The following is a description of a gene set: Human Gene Set: ZNF512_TARGET_GENES Genes containing one or more binding sites for (ZNF512) in their promoter regions (TSS -1000,+100 bp) as identified by GTRD version 20.06 ChIP-seq harmonization. studied in species Homo sapiens from publication Yevshin I, Sharipov R, Kolmykov S, Kondrakhin Y, Kolpakov F (PMID 30445619), and this is the list of marker genes: STC2, NAV2, ZNF30, OPTN, LMNB2, MSANTD4, MKRN3, JPX, GRIK5, PARP12, ANKRD24, DPF1, SEZ6L, PDE7B-AS1, MIR320B1, SLC35F5, RAB13, RNU6-1136P, KCNK15, PILRB, ALX4, SELL, EIF2S3, TLE4, PACRGL, KLHL31, NMRAL2P, GATA5, SCNN1B, RNU6-409P, CUL2, SLC25A10, INTS13 (NCBI Gene Id 55726), ZNF512B, KDM2B (NCBI Gene Id 84678), PHC1, MTA2, EPOR, APCDD1L, NIPSNAP2, GSDMA, SCARB1, RNU4-13P, HCG9, ZNF764, LINC01297, HOXC13, NINJ2, MECOM, PTPRS-AS1, ZNF180, ASPHD2, RTN3, STX2, ARL5C, PGA3, SNORD13, FYB1, LONRF3, CYP2B6, NCBP3, HIP1R, ISG20L2, POLE3, STK10, BAIAP2L1, ZNF521, POLR3H, LINC00700, LINC01596, CCDC144NL, LDAH, CD28, TG, ABHD16A, PUDPP2, SCUBE3, DENR, MRPL36, SERBP1P3, ATP6V1G2, ARL4A, NUDT5, KLF5, ARHGAP25, ZMYM3, COTL1, PARS2, CT45A1, ZNF114, ENSG00000236366, RNU2-61P, CLMN, PHLDB1, IST1, SUB1, SOD1, MARK2P11, CRYZL2P, TDRD9, MIR7845, ZNF385A, HOXB3, C4orf3, PDCL3P5, KLF7P1, TRAPPC9, AKR1B10, HMGB3P5, MIR153-1, HM13-AS1, DACH1, SOX6 (SRY-box transcription factor 6, NCBI Gene Id 84363), UGP2, CCNI, SNAPIN, GLYAT, TNFAIP3, ID2, SIRT1, LINC02798, SGK1, KLF7, ELN, CHD9NB, TGFB3, IQGAP2, SCCPDH, MDGA1, CACNA1A, CCDC83, NEK1, TIMM17A, DNM2, NEXN, NOSIP, DLGAP1-AS1, ITGAM, CHST10, HOXD3, ANPEP, HNRNPH2, GAD1 (NCBI Gene Id 50977), LRGUK, CREM, EGR3, IMPA1P1, GABBR1, ZNF528, LEISA1, NOX5, TJAP1, RNU7-196P (RNA, U7 small nuclear 196 pseudogene), HDDC2, ATP5MGP3, ZMIZ2, PPP4R3B, PGAP1, LINC02701, MYOM2, ZFP64, FSIP2LP, NAA20, RNU6-955P, ZNF184, ZC3H4, TNFRSF10B-AS1, TSPAN18, EN1, DCLRE1B, MUC16, PCED1B-AS1, NR2F1-AS1, MROH7-TTC4, TFPI, SHOX2, OR2AT1P, NIF3L1, BTN2A2 (butyrophilin subfamily 2 member A2), SLC7A6, GPC5, RBMS2, MAPKAPK2, ALG3, SMG1, NONO (NCBI Gene Id 8253), RAD51AP2, LINC03057, CYREN, SCAT1, GMFB, GALNT6, SAA1, SDC2, VAV1, BPNT1, TAF1D, RNF8, RIC8A, SPTBN1-AS2, P3H3, RNU6-845P, OR6V1, PITX3, TNFSF10, DHRS13, PRMT9, TYRO3, CHCHD10, UPF3AP2, ZC2HC1C, TRIM69, MAGEF1, NFKBIL1, TRIO, ENSG00000254718, POU6F1, ENSG00000226506, CDC123, TIMELESS, LINC02453, ZNF710, MICA, SNRNP27, FAM241B, RNU6-707P, NIFKP3, ALG1L13P, ZMYND8, EOLA1-DT, HBD, RPSAP18, TMEM160, RPL30P5, LCTL, TMEM176B, STPG1, KMO, LRRC28, PAPPA2, EFHC1, CREBL2, POLD3 (DNA polymerase delta 3, accessory subunit), PAPLN-AS1, ZFPM2, ARHGEF1 (NCBI Gene Id 9138), BET1L, ENSG00000187951, ARPC5, ZNF484, ZNF581, HOXB6, PRMT6, PCNX2, TRAPPC12, TRPS1 (NCBI Gene Id 7227), CELF3, ZNF200, SLC1A4, CCDC73, XRCC5, RIF1, ECE2, PCED1B, SLA, RCC2, HTR3D, ZYG11B, RNU6-903P, CAMKK2, MTMR9LP, NAV2-AS3, TEX11, SSBP1, C10orf53, STAU1, ITPR2, LAX1, NOP56P1, SEMA3F, AQP8, LRRC36, LYPD3, MET, GLRXP1, FOXK1, SMARCD3, IRF6, PHC2, AMPD3, FAM83A-AS2, ANGPTL4, OBI1, LINC00114, ACVR2A, WNK1, RSPO3, PRCC, PDE7A-DT, ATL2, ENC1, NIPA1, TLK1, UBTD2, AP4B1, RNA5SP243, ZNF358, FBXL2, DIP2A, ZNF580, GFOD3P, TBX15 (NCBI Gene Id 6913), SIPA1, HJV, FBLL1, KCTD19, KCTD3, DICER1, PPIL3, LARP1BP2, ZCCHC24, U2AF2, EPC1, COA6-AS1, CATSPERG, FAH, ELOCP2, KDM2B-DT, RNFT2, SCRT2, MCCC1, P2RX3, LAMP1, ATP6V1G2-DDX39B, LRRC37A3, GOSR1, XXYLT1, SMU1, GFY, LINC00836, FGF13, SPACDR, UMLILO, NAALADL2, LINC00970, PLEKHA4, PRRG2, ADD1, MINK1, RNVU1-32, H6PD, PDE7A, LIMS2, MAPK8IP1P2, CRKL, GALNT11, TCTN3, BRD7, TTI2, PTH2, GFI1B, PRTN3, CSNK1A1, SPINK4, ID2-AS1, SMG1P1, KLK10, AVL9, RPF1, SLC17A1, WEE2-AS1, ZMIZ1-AS1, RPL41, FST, LZTS1 (leucine zipper tumor suppressor 1), SOX5, RBPJL, ZCWPW1, CDKN2C (NCBI Gene Id 654235), ZNF300, PFN2, TEP1, GPR78, MYOM3, PRR7, BATF3 (basic leucine zipper ATF-like transcription factor 3), CUEDC2, CLSTN3, ETS2, NR2F1, LIPT2-AS1 (NCBI Gene Id 374408), AMIGO2, TNFRSF10B, BCL6, CCNB2, CROCC, NAPGP2, CMPK2, SMIM15P2, ARHGEF6, ZMIZ1, DKKL1, CAMK2N1 (NCBI Gene Id 55450), MTIF2, MME, TUBB8, TBX3 (T-box transcription factor 3), CRYZL2P-SEC16B, SLCO2B1, ZNF493, BRSK1, SPINT2, ACOT13, SLC25A6 (NCBI Gene Id 8283), RPS17P7, NELFCD, KRTAP16-1, SIRT4, E2F3, FAM107B, TMEM176A, PAPLN, NCOA7, KRTAP1-3, AQP4-AS1, BLCAP, STAG3L5P-PVRIG2P-PILRB, WASF1, NDUFA3P3, IDS, AJUBA (NCBI Gene Id 84962), CES3, CA8, XPNPEP2, MEPCE, PGA5, ZBTB20, PLXDC1, PTCH1, PKLR, MESP2, OR7G3 (NCBI Gene Id 390883), NFKBIE, STAG3, SEL1L3